Given this list of marker genes Mir216b (microRNA 216b), Wnt9b (NCBI Gene Id 22412), Mir216a, Mir217, Hnf1b, here is a description of the gene set: The developmental process pertaining to the initial formation of a mesonephric duct. A mesonephric duct is a tube that drains the mesonephros. studied in species Mus musculus Mouse Gene Set: GOBP_MESONEPHRIC_DUCT_FORMATION